The following is a description of a gene set: from publication Napolitani G, Rinaldi A, Bertoni F, Sallusto F, Lanzavecchia A (PMID 15995707) Genes down-regulated in comparison of unstimulated dendritic cells (DC) at 0 h versus DCs stimulated with LPS (TLR4 agonist) for 2 h. Toll like receptors (TLRs) sense microbial products and initiate adaptive immune responses by activating dendritic cells (DCs). Since pathogens may contain several agonists we asked whether different TLRs may synergize in DC activation. We report that in human and mouse DC TLR3 or TLR4 potently synergize with TLR7, TLR8 or TLR9 in the induction of selected cytokine genes. Upon synergistic stimulation, IL-12, IL-23 and Delta-4 are induced at levels 50-100 fold higher than those induced by optimal concentrations of single agonists, leading to enhanced and sustained TH1 polarizing capacity. Using microarray analysis we show that only 1.5% of the transcripts induced by single TLR agonists are synergistically regulated by combinations of TLR4 and TLR8 agonists. These results identify a combinatorial code by which DCs discriminate pathogens and provide (suggest) a rationale to design adjuvants for TH1 responses. Series_overall_design: 3 untreated, 3 treated with LPS at 2h, 3 treated with LPS at 8h, 3 treated with R848 at 2h, 3 treated with R848 at 8h, 3 treated with LPS + R848 at 2h, 3 treated with LPS + R848 at 8h studied in species Homo sapiens Human Gene Set: GSE2706_UNSTIM_VS_2H_LPS_DC_DN, and this is the list of marker genes: LINC03025, B4GALT5, BTG3, IFIH1, CXCL10, ELL2, PELI1 (NCBI Gene Id 57334), TUBB2A, TNIP1, IL12B, DEFB124, IRF8, DNAAF1, LAMB2P1, BATF, PML, DUSP2, PTGER4, APOBEC3A, RASSF5, ARL5B, RASGRP1, IL10RA, PXDC1, TENT4A, TAP1, INSIG1, SOCS3, TRAF1, P2RY2, NAMPT, PIK3R5, DEPP1, TRIM26, DUSP5, RAB30, NFKB1, ITGB8, SPRED2, MIR3945HG, MSANTD3, JAG1, GADD45A, PATJ, ISG15, GPR183, IFNB1, ADA, TNFAIP3, IFI44, BCL2L1, CD274, LRRC32, RILPL2, CXCL11, HCAR3, MFSD2A, PIM3, CSRNP1, P2RX7, MARCKSL1, WNT2, PLAGL2, MIR3142HG, NINJ1, NEMP1, GPR132, NUP98, TNFAIP8, EZH2, IRF7, EFNA1, CD80, MAP2K3, CXCL1, DCUN1D3, NABP1, SIAH2 (NCBI Gene Id 6478), CXCL2, PTPN5, SAR1A, GEM, LAMP3, IL18RAP, EDN1, TNFAIP6, GATA6, ISG20, KDM6B, IL10, TNIP2, IFIT1, CREB5, BIRC3, GMEB1, ZC3H12A, TMEM150C, HS3ST3B1, LTA, NFKBIZ, C17orf58, SIPA1L1, KCNJ2, PLAUR, CYTOR, IFIT3, EHD1, RELB, RMST, NCF1C, MIR9-1HG, PTPN1, GPR45, MAP3K8, PARP14, HES4, TNFAIP2, IRAK2, KCNH2 (NCBI Gene Id 4027), ATF5, TDH, STX11, FXYD6, USP12, RIPK2, CDKN1A, CFLAR, HOATZ, TP53BP2, HERC6, ENSG00000284634, GADD45B, ZC3HAV1, ZNF697, PTP4A3, ZNFX1, SLC2A6, IL23A, OASL, SPAG1, ERICH1, KRTAP4-9, ABCC11, ANKRD33B, RAB21, SNHG15, RAPGEF2, REL, MGC4859, SOD2, TNFRSF4, IL36G, BTG1, TTN, BTG2, BID, PAPPA2, RGS1, C15orf48, GALNT3, CRLF2, ICAM1, ETV3, CITED1, TP53INP2, ZNF385B, LDLR, C17orf78, IL6, NFKBIA, MIR155HG, PTGIR, CXCL3, INHBA, IL1A, SELENOK, FAM43A, HIVEP1, SHROOM4, TNIP3, GBP1, SLC43A3, RAB7B, NR4A3, ATF3, ACSL1, CCRL2, IRF1, UBE2Z, TTYH2, RNF144B, NFKBIB, OTUD1, EPM2AIP1